Given this list of marker genes Kcnq5, Kcnc1, Kcnc3, Kcna6, Kcns1, Kcnc4, Kcnh8, Kcnb2, Kcnf1, Kcnh5, Kcnab3, Kcng1, Kcnh6, Kcnd1, Kcna5, Kcng3, Kcnh7, Kcna1, Kcnd3, Kcnc2, Kcnd2, Kcnh2, Kcnh3, Kcna10, Kcnb1, Kcnh1, Kcns2, Kcna2, Kcnab1, Kcna3, Kcnq4, Kcnv2, Kcng4 (potassium voltage-gated channel, subfamily G, member 4), Kcna7, Kcna4, Kcnab2, Kcnh4, Kcns3, Kcnq1, Kcnv1, Kcng2, here is a description of the gene set: Voltage gated Potassium channels Mouse Gene Set: REACTOME_VOLTAGE_GATED_POTASSIUM_CHANNELS species: Mus musculus